Given this list of marker genes Slc1a1, Gnas, Htr2a, Oprd1, Htr4, Prkd1, Rnls, Oprm1, Sin3a, Klf16, Prmt5, Ncstn, Nr1h4, Gna11, Htr3b, Htt, Lrrk2, Vps35, Nr4a3, Drd4, Htr3a, Htr2c, Adcy6, Gnal, Gk, Adrb2, Htr7 (NCBI Gene Id 15566), Gnai3, Alk, Hcn3, Gna15, Drd3, Atp1a3, Nherf1, Rgs4, Gna14, Rgs8, Ptger1, Cav2, Gper1, Rgs9, Drd5 (NCBI Gene Id 13492), Fcsk, Comt, Gnaq, Htr1a, Adcy5, Gm527, Palm, Dnm2, Dtnbp1, Flna, Htr6, Gnb5, Taar1, Gnao1 (NCBI Gene Id 14681), Aplp1, App, Drd2, Tgm2 (NCBI Gene Id 21817), Drd1, Htr2b, here is a description of the gene set: Mouse Gene Set: GOBP_RESPONSE_TO_MONOAMINE studied in species Mus musculus Any process that results in a change in state or activity of a cell or an organism (in terms of movement, secretion, enzyme production, gene expression, etc.) as a result of a monoamine stimulus. A monoamine is any of a group of molecular messengers that contain one amino group that is connected to an aromatic ring by ethylene group (-CH2-CH2-). Monoamines are derived from the aromatic amino acids phenylalanine, tyrosine, histidine and tryptophan.